The following is a description of a gene set: Mouse Gene Set: GOCC_T_TUBULE studied in species Mus musculus Invagination of the plasma membrane of a muscle cell that extends inward from the cell surface around each myofibril. The ends of T-tubules make contact with the sarcoplasmic reticulum membrane., and this is the list of marker genes: Capn3, Slc9a1, Kcnd2, Cacng6, Akap7, Scn1b, Atp2b4, Kcnj3, Ppp3cb, Atp1b1 (ATPase, Na+/K+ transporting, beta 1 polypeptide), Adra1b, Cltc, Cav3, Atp1a1, Dlg1, Ednra, Adra1a, Cacna1c, Scn2a, Kcnn2 (potassium intermediate/small conductance calcium-activated channel, subfamily N, member 2), Sri, Ank2 (NCBI Gene Id 99906), Cacnb1, Scn1a, Tmem151a, Cdh2, Cacnb3, Esr1, Stac3, Ryr1, Slc8a1, Stbd1, Kcnj5, Oprk1, Nos1, Prkar2a, Ezr, Cacng7, Cacna1d, Abcc9, Aqp4, Oprm1, Cacna1s, Tgfb3, Clcn1, Rem1 (NCBI Gene Id 319709), Prkce, Nos1ap, Casq1, Rrad, Vdr (NCBI Gene Id 22337), Cacna2d1, Akap6, Got2, Kcnj11, Cacng4, Kcnj12, Msn, Camk2d, Ank3, Scn5a, Dysf, Bin1, Stac, Slc2a4, Rdx, Igf1r, Fxyd1, Cacng8, Atp1a2, Scn2b, Slc30a1, Rtn2, Cacnb2, Cacng1, Kcnj2